Given this list of marker genes NDRG3, DXO, FAM219B, WDR48, SIDT1, GPT2, COQ8B, TCP11L2, LY9, LIME1, QSOX1, DHDDS, NCOA4, PCMTD2, BCL7B, CAPZB, ZDHHC5, WRN, TBC1D25, SIGMAR1, NUP155, USE1, PNKP, ERP29, RFXANK, ATF6B, SUPT5H, GPI, KPNA3, INIP, WIPI2, CYB561D1, METTL6, LMNB1, SQSTM1, UBE4A, APEH, MYL6, SYTL1, KCNJ15, LRRC42, CRLS1, FLOT1, PPP2CB, INO80E, DMAC2, FLCN, DECR2, DYNC1LI2, ACADS, TM6SF2, MAGEB5 (NCBI Gene Id 347541), NSUN4, TMEM38A, RELA, ZNF414, SLC35A2, ELMOD3, PABPC4, BDKRB2, TSEN34, TMEM183A, FTO, SPATA6L, TTLL5, CCS, GP9, PARP3, CORO1A, PPP5C, TPRA1, RNF181, ACTG1, BIN1, KLHDC3, CABCOCO1, VPS35L, FBXO2, ACTR1A, RAE1, PRAMEF8, ADCY10, CCDC65, RANBP17, GUSB, NUB1, KATNB1, SLC7A5, NDST2, GALC, RPL3L (NCBI Gene Id 6123), BTRC, ALDOA (aldolase, fructose-bisphosphate A), NRBP1, STAU1, GALT, CYP2D6, VPS18, GIGYF2, CPN2, AKAP8, RANBP6, STX4, TRAF6, DCTN5, NEIL1, FXR2, SAXO5, RNF25, USP8, ITGA5, TREX1, NPR2, RNF114, VPS51, GSDMD, NECAP2, LAG3, RAPGEF3 (NCBI Gene Id 27105, Rap guanine nucleotide exchange factor 3), NKIRAS2 (NFKB inhibitor interacting Ras like 2), OXA1L, ACTR8, VEGFC, ECH1, GLIPR1, ELMO1, VPS26A, UBE2Q1, GNGT2, DDB2, ARMH3, COMMD4, CMTM3, METTL17, MOB2, NAA40, NXPE3, GRB2 (NCBI Gene Id 80715), HMCES (NCBI Gene Id 56941), C1QTNF12, AIM2, GPS1, PRKCSH, CHKB, HEATR6, RNF167, PPIL2, LIPE, C5orf34, COPG1, CHCHD5, SEPTIN6, HIPK1, KIF1A, PPME1, ALDH2, ITPKC, NCKAP1L, CCT8L2, COMMD5, EML2, PRKAB1, BCL2L12, DLAT, TM9SF1, SLC11A2, TNFRSF11B, NELFB, SRSF10 (serine and arginine rich splicing factor 10), ZNF146, KLHL11, EFHC1, TOMM34, ACAA1, PLEKHN1, NIT1, PIK3IP1, GNPNAT1, ANKRA2, ZFPL1, EDN2, TRIM11, APBB1IP (amyloid beta precursor protein binding family B member 1 interacting protein), BDH1, RNF4, C1GALT1, SAR1A, TTC4, ANKRD42, COX6B2, ZFAND6, TIE1, MED24, ARHGAP15, PPDPF, FLRT3, PFN4, SMARCB1, DOK1, FGFR1OP2, here is a description of the gene set: from publication Szanto A, Balint BL, Nagy ZS, Barta E, Dezso B, Pap A, Szeles L, Poliska S, Oros M, Evans RM, Barak Y, Schwabe J, Nagy L (PMID 21093321) Genes down-regulated in macrophages (12h): IFNG, TNF and rosiglitazone versus IFNG and TNF. Human Gene Set: GSE16385_ROSIGLITAZONE_VS_UNTREATED_IFNG_TNF_STIM_MACROPHAGE_DN studied in species Homo sapiens Human CD14 positive monocytes were purified from healthy volunteers’ blood and cultured in vitro for 4, 12, 24, 72 hours. While culturing, macrophages were activated alternatively with interleukin-4 (IL-4 100 ng/ml) or classically with interferon-gamma (IFNg 100 ng/ml)+tumor necrosis factor (TNF 50 ng/ml) or left without activation. Simultaneously, macrophages were also treated with vehicle (DMSO:ethanol) or 1mM synthetic PPARg agonist, Rosiglitazone. We used Affymetrix microarrays (U133Plus 2.0) to analyze activation and PPARg-induced gene expression changes.